The following is a description of a gene set: Human Gene Set: HP_ABNORMAL_SERUM_INSULIN_LIKE_GROWTH_FACTOR_1_LEVEL studied in species Homo sapiens An anomalous level of insulin-like growth factor 1 (IGF1) in the blood circulation. Abnormal serum insulin-like growth factor 1 level, and this is the list of marker genes: SLC35C1, MED12, NFKB2, AIP (aryl hydrocarbon receptor interacting protein), GHRHR, IGF1, DCAF17, GHR, SOX3, STAT5B, RBM28, KIAA0753, GH1, DNA2, MCTP2, IGFALS, PGM1, GALT, MPDU1, IGF1R, SIK3, SMPD1, ROBO1, CTSK, ALG12, PDE11A, PRKAR1A, ADAT3, MEN1, GHSR, GPR101